The following is a description of a gene set: Human Gene Set: MIR4657 Genes predicted to be targets of miRBase v22 microRNA hsa-miR-4657 in miRDB v6.0 with MirTarget v4 prediction scores > 80 (high confidence targets). from publication Chen Y, Wang X (PMID 31504780) studied in species Homo sapiens, and this is the list of marker genes: USP15, AFF4, TTI2, YOD1, WNK1, GMEB1, FAM222B, LIPG, PLEKHB2, VBP1, CCDC6 (coiled-coil domain containing 6), YWHAQ, GATAD1, FZD6 (frizzled class receptor 6), STEAP3, HMCN1, LATS2, DYNC1I1, ALCAM, ZFP36L1, RASA1 (NCBI Gene Id 5921), DISC1, PAXBP1, C8orf34, IP6K2, C6orf120, OCLN, AGTR1, MID1 (midline 1), CLTC, RGS4, DNAJA2, KIAA1671, PLPPR5, PHIP, ATP8B4, TRIP13, TMEM132B, SPACA7, CKLF, RMDN2, SEMA6A, ABHD17C, ZNF548, NIPSNAP2 (NCBI Gene Id 2631), ZNF532, RORA, TNFSF15, HTR5A, SOX10, ANXA7 (NCBI Gene Id 310), HIVEP2, MAPKAPK5, GRIN2D, LRRTM2, PDCD6IP, APLF, GLCCI1, ZDHHC15, SANBR, ASPH, PYGO1, CCNT2, GSPT1, SIGLEC8, PRPF4, CNIH1, KLC4, TFB1M, CA8, OR11A1, RPL26L1